The following is a description of a gene set: part of: APC/C-mediated degradation of cell cycle proteins species: Homo sapiens Reactome Pathway: Autodegradation of Cdh1 by Cdh1:APC/C Cdh1 is degraded by the APC/C during in G1 and G0. This auto-regulation may contribute to reducing the levels of Cdh1 levels during G1 and G0., and this is the list of marker genes: UBE2S, ANAPC2, ANAPC4, ANAPC11, PSMD12, PSMB6, UBC, UBB, PSMA6, PSMA2, PSMD7, PSMC5, PSMB7, ANAPC16, CDC23, PSMB3, PSMC2, PSMB4, PSMB2, UBE2D1, UBA52, PSMD8, RPS27A, PSMC4, ANAPC10, PSMD2, PSMC6, ANAPC1, PSMC1, PSMD13, PSMA5, ANAPC7, ANAPC5, PSMA3, PSMD14, PSMD11, CDC27, CDC16, PSMD6, ANAPC15, SEM1, PSMA7, PSMD1, CDC26, PSMB5, ADRM1, UBE2E1, PSMA1, PSMC3, PSMA4 (NCBI Gene Id 5685), UBE2C, PSMD3, PSMB1, FZR1